The following is a description of a gene set: studied in species Homo sapiens Human Gene Set: GOBP_GROWTH_PLATE_CARTILAGE_CHONDROCYTE_DIFFERENTIATION The process in which a chondroblast acquires specialized structural and/or functional features of a chondrocyte that will contribute to the growth of a bone. A chondrocyte is a polymorphic cell that forms cartilage., and this is the list of marker genes: COL27A1, RARG, MATN1, IFT80, SOX9, POC1A, TGFBR2 (NCBI Gene Id 7048), ATF2, TSKU, NPPC